The following is a description of a gene set: Human Gene Set: GSE1925_CTRL_VS_3H_IFNG_STIM_IFNG_PRIMED_MACROPHAGE_UP from publication Hu X, Park-Min KH, Ho HH, Ivashkiv LB (PMID 16148108) IFN-gamma transcriptional responses in control and IFN-gamma primed primary human macrophages studied in species Homo sapiens Genes up-regulated in macrophages primed by IFNG: untreated versus stimulated by IFNG for 3h., and this is the list of marker genes: MROH1, ZFC3H1, SLC8B1, S1PR4, BTD, LINC00299, PPP1R11, ZFYVE1, CDK14 (NCBI Gene Id 5218), H3C3, SDC2, ARL5A, ARPP19, BCAS3, KRT4, PRDM14, PRKCZ, LINC00616, LOXL4, ZNRD2-DT, CASP8, LINC00847, PIGG, NHLRC3, FBXO8, FKBP15, ATP6V0A1, TMT1A, PTAFR, SLC7A11-AS1, ACTL7A, RAB11A, DBP, SMCO4, LIN52, NOL3 (NCBI Gene Id 8996), EIF2B1, ACADS, LZTFL1, ALDH8A1, GAB3, LINC00221 (NCBI Gene Id 338005), PLCB4, LY86-AS1, KCNMA1, MAOA (NCBI Gene Id 441491), KRT2, EML3, PSTPIP2, SLC22A18, WAS, LMBRD1, ZNF385A, MAT2B, ZKSCAN3, MYO18B, KCTD11, DHRS12, GSTP1, LPCAT1, H6PD, SAT2, YIPF3, LMTK2, RPL13A, GPI, HBP1, VPS52, TRIM38, TMED6, NICOL1, ZAP70, KIR2DS3, CERT1 (NCBI Gene Id 10087), AUH, RPS2, RPL34, KCNE3, CD99, SSR4, SERPINI1, NMNAT2 (NCBI Gene Id 23057), NDUFA4, SLC35E2A, TXN, DPM3, ANKRA2, COL19A1, RPL41, PTPMT1, CCDC142, ST6GALNAC2, TAF7, FAM223B, ARIH1, GPR135, CNOT4, FIG4, MARCHF11, TKT, MYH14, PLCG2, CFAP47 (cilia and flagella associated protein 47), BCOR, ITM2B, NANOS1, HEY1, THOC7, REEP6, CATSPER1, HPCA, SH3BGRL, SAG, CHID1, INPP5K, PGD, ZNF444, GABARAPL1, ATXN7, ATCAY, AGBL4, HVCN1, TBC1D2B, LY96, ARAP1, OR1F2P, ABCG2, LINC00887, EDEM1, TMEM117, IRAK3, P4HB, HEATR5A, GPR174, OBSL1, H2AC17, LINC00324, MCU, GK3, GRIN3A, SLC5A5, KLHL9, GOLGA7 (NCBI Gene Id 51125), ZMAT3 (zinc finger matrin-type 3), IFNAR2, MXD4, IFIT2, SMARCC2, APOBEC4, CACUL1, KCNIP1, GPA33, ACACA, SRPRA, CA6, MIF4GD, RPL22, GPAT4, ARL11, EIF4A2, SOX21, MRPL37, TECR, SLC25A48-AS1, OPRK1, KLHL21, METRN, GCA, TMEM254, CYFIP2, CSTPP1, RPP25L, SLC31A2, LRP10, LINGO3, NUB1, DHRS7, SUSD6, GTF3C3, PRICKLE1, TTTY13, HLA-DRB4, TRADD, CNOT8, KBTBD2, CHST11, NEB, RPL27A, MDK, PRDX6, CFLAR-AS1, ZSCAN4